Given this list of marker genes C3AR1, C1QA, SLC39A13-AS1, IGSF6, SCN1B (NCBI Gene Id 6324), WFDC21P, S100A12, CXCR2P1, FGR, SCIMP, BCL2A1, RPL32P1, S100A8, CD1D, COL4A3, RN7SL368P, LUCAT1, NFAM1, PROK2, SIGLEC5, PTCRA, NME8, HLA-DRB5, SLC37A2, VSIG4, TIFAB, LILRA1, OSCAR, CD86, CD300LF (NCBI Gene Id 146722), CCDC26, CLEC5A, CPVL, MSR1, PLEK, GPR35, LINC00892, ABCA13, IL10, RN7SL288P, S100A9, FCER1G, HELZ-AS1, GNA15, ENSG00000230709 (NCBI Gene Id 284191), IRF5 (NCBI Gene Id 84729, interferon regulatory factor 5), LILRB4, CLEC9A, MS4A14, SCT, CCDC170, FMN1 (formin 1), HLA-DRB9 (major histocompatibility complex, class II, DR beta 9 (pseudogene)), SPI1, CARD9, HCAR3, C1orf162, CSF3R, LYZ, CLEC10A, ZNF385A, CLEC7A, CFP, SLAMF7, VENTX, IL1B, STYXL2, CAMP, SOWAHD, SIGLEC14, MRC1, FOLR2, HK3, CX3CR1, GPR141, CD300LB, CD300E, CXCL8, TREM1, MS4A7, LILRA5, NLRP12, CEACAM4, ATP8B4, RN7SL138P, OGFRL1 (opioid growth factor receptor like 1), ITGAX, NLRP3, LRRC25, JAML (junction adhesion molecule like), MS4A4A, MS4A6A, ENSG00000258657, MIR3945HG, MS4A4E, GPR82, FCN1 (NCBI Gene Id 2219), MEFV, CYBB, HLA-DQB1, CLEC4A, FPR3, PLD4, UTF1, ENSG00000267694, FCAR, ENAM, LINC00299, SLC24A4, NCF1, C5AR1, TFEC, LILRB3, HCK, LINC00996, LINC01478, CD83, PACSIN1, LINC02908, SLC22A20P, HLA-DQA1, HMGN1P15, NCF2, CD163L1, S100Z, PRTN3, P2RY13, CSTA, TYROBP, SIGLEC10, MCOLN2, SIRPB2, FAM221B, SIGLEC9, CD300C, IDO1, SRGN, WNT10B (NCBI Gene Id 82499), TLDC2, MILR1, CD68, VNN3P, ADAM28, TNNI2, LILRB1, HPGDS, CD14, NLRC4 (NCBI Gene Id 58484), FGL2 (fibrinogen like 2), ENSG00000226571, UPK3A, CSF2RA, ASGR2, P2RY6, AQP9, LINC03070, CCR5, GPR34, PILRA, NAPSB, SIGLEC7, TRPM2, DEFA3, HMOX1, SIGLEC1, F13A1, CLEC4C, GZMB, LST1, RENBP, LILRB2, PADI4, FPR1, KCNE1, HLA-DRB6, LGMN, TIMD4, JCHAIN, IL1RN, LILRB5, RNU4-38P, LINC02132, CD209 (NCBI Gene Id 30835), C1QB, RASGRP4, MICOS10-DT, SLC31A2, CLEC12A, SLAMF8, CD163, TASL, ITGAM, FCGR2A, SMIM35, SPNS3 (NCBI Gene Id 201305), LILRA6, MNDA, FLT3, PRAM1, PADI2, MYO1F, CCR1, FCGR1A, TLR8, HRH1, RNASE6, TBXAS1, HLA-DQB2, CCR2, KCNK13 (NCBI Gene Id 56659), CD33, C1QC, ADGRE2, LGALS12 (NCBI Gene Id 85329), ARL5C, IFI30, LIPN, RETN, PTAFR, BATF3, HLA-DRB1, LILRA4, CTSZ, SIGLEC11, CLNK, LINGO4, HLA-DPA1, RGS18, IL1R2, MPO, MPEG1, C19orf38, XCR1, OSM, KYNU, CSF1R, AGR2, FGD2, SIRPB1, here is a description of the gene set: Marker genes curated from the annotated cluster as represented in the Descartes Human Gene Expression During Development database. from publication Cao J, O'Day DR, Pliner HA, Kingsley PD, Deng M, Daza RM, Zager MA, Aldinger KA, Blecher-Gonen R, Zhang F, Spielmann M, Palis J, Doherty D, Steemers FJ, Glass IA, Trapnell C, Shendure J (PMID 33184181) The gene expression program underlying the specification of human cell types is of fundamental interest. The study authors generated human cell atlases of gene expression and chromatin accessibility in fetal tissues. For gene expression, the study authors applied three-level combinatorial indexing to >110 samples representing 15 organs, ultimately profiling ~4 million single cells. The study authors leveraged the literature and other atlases to identify and annotate hundreds of cell types and subtypes, both within and across tissues. Our analyses focused on organ-specific specializations of broadly distributed cell types (such as blood, endothelial, and epithelial), sites of fetal erythropoiesis (which notably included the adrenal gland), and integration with mouse developmental atlases (such as conserved specification of blood cells). These data represent a rich resource for the exploration of in vivo human gene expression in diverse tissues and cell types. Human Gene Set: DESCARTES_FETAL_PANCREAS_MYELOID_CELLS studied in species Homo sapiens